The following is a description of a gene set: Human Gene Set: PETRETTO_LEFT_VENTRICLE_MASS_QTL_CIS_DN from publication Petretto E, Sarwar R, Grieve I, Lu H, Kumaran MK, Muckett PJ, Mangion J, Schroen B, Benson M, Punjabi PP, Prasad SK, Pennell DJ, Kiesewetter C, Tasheva ES, Corpuz LM, Webb MD, Conrad GW, Kurtz TW, Kren V, Fischer J, Hubner N, Pinto YM, Pravenec M, Aitman TJ, Cook SA (PMID 18443592) Down-regulated cis-regulated expression quantitative loci (cis-eQTL) in the heart that were identified as candidate genes for the regulation of left ventricle mass (LVM). studied in species Rattus norvegicus Left ventricular mass (LVM) and cardiac gene expression are complex traits regulated by factors both intrinsic and extrinsic to the heart. To dissect the major determinants of LVM, we combined expression quantitative trait locus1 and quantitative trait transcript (QTT) analyses of the cardiac transcriptome in the rat. Using these methods and in vitro functional assays, we identified osteoglycin (Ogn) as a major candidate regulator of rat LVM, with increased Ogn protein expression associated with elevated LVM. We also applied genome-wide QTT analysis to the human heart and observed that, out of 22,000 transcripts, OGN transcript abundance had the highest correlation with LVM. We further confirmed a role for Ogn in the in vivo regulation of LVM in Ogn knockout mice. Taken together, these data implicate Ogn as a key regulator of LVM in rats, mice and humans, and suggest that Ogn modifies the hypertrophic response to extrinsic factors such as hypertension and aortic stenosis., and this is the list of marker genes: NSD1, SEMA4D, KLHL3, SFXN1, ZNF346, CENPP, FAF2, TSPAN17, AGTPBP1 (NCBI Gene Id 23287), ISCA1, QNG1